The following is a description of a gene set: Abnormality of the wrist, the structure connecting the hand and the forearm. species: Homo sapiens Human Gene Set: HP_ABNORMALITY_OF_THE_WRIST Abnormality of the wrist, and this is the list of marker genes: TBX15, PIEZO2, FLNB, IDH2, FGFR2, ERCC1, COL6A1 (NCBI Gene Id 1291), ABCC6, ANO5, SCYL2, DDR2, ASXL1, DLK1, SMOC1, PDE4D, ESCO2, ATP7A, RECQL4, RBM8A, COL2A1, CYP2R1, ZMYM3, EIF2AK3, SLC35D1, TRAPPC2, EVC2, SIK3, TBX5, COMP, SLC35B2, PIGV, SLC34A3, GLB1, GLI1, TONSL, MACROH2A1 (NCBI Gene Id 9555), B3GALT6, PTH1R (NCBI Gene Id 5745), PTPN22, PRG4, NALCN, NXN, STAT4, TBX3, EXTL3, PAX3, PSMD12, IL2RA, GNPTAB (N-acetylglucosamine-1-phosphate transferase subunits alpha and beta), BMPR1B, SPG11, TNNI2, GPC4, IHH, EXOC6B, XRCC2, WNT7A, NOG, DMP1, MMP2, DYNC2LI1, PTPN2, HSPG2, COL25A1, CBFB, ANKRD55, ERGIC1, PITX1, TNNT3, GDAP1, EXT2 (NCBI Gene Id 2132), BPNT2, SALL4, CADM3, LTBP3, PRKACB, TRIP11, MYH3, NANS, CHSY1, GNE, FLNA, AEBP1, CHST3, TRPV4, GDF5, CAPN3, COG4, DHX16, COL27A1, MAP3K7, COL6A2, EBP, UFSP2, VDR, AIFM1, MEG3, MUSK, SLC34A2, ADGRG6, FBLN1, TUBB3, BHLHA9, EVC, TPM2, CD247, MAFB, ENPP1, LEMD3, NIN, PI4KA, OCRL (NCBI Gene Id 4952), ROR2, OPA3, CYP27B1, MYL11, GJA1, KIF22, BGN, HOXA13, ASAH1, MATN3, BPTF, IDH1, SHOX, COL7A1, GALNS, RSPRY1, RAC3 (NCBI Gene Id 5881), TNNT1, PRKACA, NOTCH2, EXT1, LAMB2, CANT1, SHH, FGFR3, IL2RB, HOXD13, RTL1, APC, AKT1, MECP2, COLQ, COL12A1, COL6A3, DYM, FBN2, POR, KIDINS220, SLC10A7, LONP1, LMNA, ALDH18A1, ALG12, FILIP1, ERLIN2, MBTPS1, CLCN5, SETD2, ZMPSTE24, LMBR1, LRP4, RMRP, ADAMTSL2, XYLT1, CCN6, MMP14, GPC3